Given this list of marker genes CHL1, KMT5B, PCDHA13, RBM4B, TAF6, SGSM1, BTG2, PCDHA11, LMX1A, HIPK3, MBD2, ATM, SV2C, GATA2, PALLD, LHFPL4, ZBTB43, R3HDM1, WWC1, ZNF266, MTOR, CAMTA1, SESN1, CIMIP2A, PHAF1, CNN3, RBM45, HIVEP2, FAM193A, ZEB2, CD177, GNAI3, PLEKHA1, CTNND2, PCDHA7, MCPH1, SYN2, SYN3, SHCBP1, SRPK1, TIAM1, LAMTOR3, SEC62, PAN3, PDS5A, TM2D3, SBNO1, PCDHA9 (NCBI Gene Id 9752), ADSL, VAPA, KLB, HIVEP3, ZNF507, PCDHA1, WDFY3, BCL2L11, NPTN, CENATAC, IL1R1 (NCBI Gene Id 3554), CYRIB, TMEM117, SLC3A1, CAB39, BNC2, EIF4E, MMP15, ASB7, MEGF9, TMEM185A, FRS2, TJP1, PCDHA10, DLG2, CACNB4, PCDHA5 (protocadherin alpha 5), IGFBP7, GPBP1L1, PCDHA2, VSIG1, PPM1A, ARHGEF10, SIK3, PCDHA3, KDM5B, MGAT2, NRXN1, MAK, SLC38A2, RAG1, GABPB1, ZNF747, UBE2F, PCDHAC2 (NCBI Gene Id 92387), STK3, PCDHAC1, SOX11, PCDH20, SRRM2, GABRB2, PCDHA6, HECW2, CTCF, PCDHA12, RGS13, PCDHA4, here is a description of the gene set: Human Gene Set: MIR4718 Genes predicted to be targets of miRBase v22 microRNA hsa-miR-4718 in miRDB v6.0 with MirTarget v4 prediction scores > 80 (high confidence targets). species: Homo sapiens from publication Chen Y, Wang X (PMID 31504780)